The following is a description of a gene set: from publication Chen Y, Wang X (PMID 31504780) studied in species Homo sapiens Genes predicted to be targets of miRBase v22 microRNA hsa-miR-12123 in miRDB v6.0 with MirTarget v4 prediction scores > 80 (high confidence targets). Human Gene Set: MIR12123, and this is the list of marker genes: MMP2, GLT8D2, WDR43 (WD repeat domain 43), SCAF4, SLC14A1, RNF103-CHMP3, TBC1D3B, OGFR, DMGDH, CFAP20, FAM200C, ADGRB3, PPP4R4, KIAA1549L, ZC3H12C, ZNF570, ANAPC11, VAMP7, CD163L1, FUT2, ZNF597, MGA, TPR, RPS6KA5, CDK12, SLC7A2, MGAT2, CUZD1 (CUB and zona pellucida like domains 1, NCBI Gene Id 50624), PLCXD3, TFPI2, TMEM59, LGI2, RNF157, SLC10A7, ADCYAP1, ALKBH1, TIGIT, ENKUR, GRB2, PTPDC1 (NCBI Gene Id 138639), NBL1, BACE2, ABRAXAS2, C9orf72, GNRHR (gonadotropin releasing hormone receptor), FMN2, FAM98A, SYT4, SELENOT, FBXO33, GBX2, SKA2, DCDC2, SC5D, UBE2H, GOLIM4, WEE2, CCDC88A, TMEM255A (transmembrane protein 255A), PAQR8, E2F4, SLPI, STT3A, RUNX2, MEP1A, MSR1, CT47A4, SEC62, ITPRID2, GCSAML (germinal center associated signaling and motility like), PSMC6, TBX1, FBXL3, GPR37, USP46, FABP4, CAVIN4, KCNV1, RAB2A, CT47A12, ANO3, SPSB4, ARHGAP6, SLC16A6, COMMD3-BMI1, CAP2, CPE, MPV17L, NCKAP5, PRDM8, ARID1A, CEP20, CT47A11, NUP50, YES1, B3GALNT2, ZNF608, C1D, IRAK3, IFNG, CUL9, UNC80 (unc-80 homolog, NALCN channel complex subunit), REV3L, DYRK1A, LYSET (lysosomal enzyme trafficking factor), MDC1, FUT9, DYNLT5, TNFRSF19, SYT16, UBE2Q2, SLC23A2, MAN1C1, CWC27, SAMD4B, CNTN5, PPP1R12A, CDO1, PPM1L, UGT2B10, ZEB2, HEATR5B, MPDZ, EZH2, KIF3A, PI4K2A, PTPRF, TNPO1, CCDC71L, ADAMTS9, TMX4, ULK2, CDKL2, CNIH2, NR4A2, SUPT6H, CYREN, ZBTB41, HSPA13, TTC14, C8orf34, RB1CC1, QKI, ERLEC1, LZTR1, DAZ2, SSMEM1, SSH2 (NCBI Gene Id 85464), NEK2, ADAM12, SYNRG, RAB9B, NSG1, MAP2, ZNF519, DDX54, NOL3, LYPD6, JAG2, SLC6A15, PAX3, MESP1, SVOPL, GABRA4, SYNE2, TRPA1, ENPP3, MOB1A, MAP3K2, CNGA1, MARK1, NIBAN1, SREK1, LHFPL6, IL17RE, FZD3, NPY2R, PLCB3, RBM26, PRTG (protogenin), PTPN22, MED13, TMEM260, HP1BP3, ATP11C, RAD23A, DENND1B, RRAGA, ZNF737, KBTBD3, SNTG1, IGSF9, GPHN, ZNF678, RAB5IF, PPP1R3A, HS6ST3, KLHL2, USF3, ERP44, SERP1, CFDP1, SIVA1, DOCK5, FRA10AC1, PTPN20, TAF1D, DISC1, C2orf88, MAPK8 (NCBI Gene Id 5599), CDH19, TMX3, ABHD11, BTNL9, TMEM69, NLK, RPRD1B, MYOG, PLP2, GATA3 (GATA binding protein 3), HNRNPDL, NEGR1, CT47B1, SLC25A40, ZNF684, BMI1, GPRASP1, RAB12, IMMT, FTH1, ABHD18, FSTL1, HSF2BP, PRG4, MCM8, MID2, MTMR9, ARHGAP33, DAZ4, VAV2, EYS, DELE1, DCUN1D5, RPL26L1, PSIP1, CT47A8, BCAR3, SRSF4, DBT, BMPR2, SLC15A5 (solute carrier family 15 member 5), CAMSAP2, ANGPT2, MAT1A, BAAT, PHLDA1, SH3TC2, USP5, CREB1, UBE2B, VDAC2 (NCBI Gene Id 7417), ZNF704, SYPL2, GINS4, ELOVL4, NCS1, GPATCH4, BCL2A1, MOB1B, CDC14A, TMEM65, ITGB8 (NCBI Gene Id 3696), ELMOD1, SSNA1, TTC33, CNTN3, GABRB2, MYO19, KMT2C, CEP43, CCR1, ARMCX3, FOXO4 (NCBI Gene Id 4303), STRC, TNFSF8, UBN2, FLRT3, MAT2B, AHCTF1, MTMR6, CMTR2, KIF12, ATP5MG, SCAF11, RNF26, ENAH, SLC17A5, KCMF1, XPNPEP1, TMPO, ADH4, GCSAM, MSC, FOXO6 (forkhead box O6), CRHBP, DST, PLEKHA3, SLC16A7, ALDH6A1, DIXDC1, BEND4, ZNF227, KCNH2 (potassium voltage-gated channel subfamily H member 2), CT47A3, RBM41, PBX3, CT47A9, PCDHB11, BCL2L11, ALDH1L2, LRRCC1, ZNF22, DOCK10, UBE2D3, CWC22, ODR4, DAZ1, SLC1A2, FBXO43, RNF40, PTER, EIF4A1, HAS2, OCRL, MPP4, ACVR2A, TRMT5, SCAI (NCBI Gene Id 286205), RTN1, MDM1 (NCBI Gene Id 56890), DZIP1, LRRC8B, STK38, EIF2S2, EGFLAM, ZSWIM2, OGA, TMEM131L, CT47A7, NUFIP2, LZTS1, CBR4, DIAPH3, CT47A2, ZNF579, IDS, TFRC, NCAPD2, EFNA5, GNL1, CFAP52, RPS6KA6, CREBRF (NCBI Gene Id 153222), G3BP1, SLC25A32, TBX15, MTERF3, TRPS1, SPA17 (sperm autoantigenic protein 17), LEFTY1, YOD1, CSNK1G3, SLC30A10, NUDT19, HAPSTR1, SPATA6, TNIK, JADE1, SLC25A27, SPPL3, TPP2, SERTM1 (NCBI Gene Id 400120), SYNPR (synaptoporin), GAL3ST4, CCDC50, TMEFF2, LRCH2, POLR1F, RPS6KA3, CA8, STK35, LMO7DN, AUH, ZNF585B, NEFM, SLITRK4, PTP4A2, GFPT1, AFAP1, SLC10A4, ZNF544, MERTK (MER proto-oncogene, tyrosine kinase), SQOR, GARNL3, CXADR, CACNA2D1, SBSN, C5orf15, ZNF423, EDRF1 (erythroid differentiation regulatory factor 1), DCLK3, CT47A1, MYOM1, PPP3R1, SMC5, PKP4, RFC3, GPR180, KIF5C, CHMP3, PTPRC, NMB, TNFAIP8, ELAPOR2, STAG2, FKRP, EHMT1, ZC3H12B, NRG1, FAR1, IREB2, CNBP, A2M, RRH, HSD17B6, ZNF572, MARCHF2, PDLIM2, SLC4A2, ZFP30, ERO1A, PRKG1 (NCBI Gene Id 5592), PUS10, HNRNPD, GTF2A1, ADGRL3, GABBR2, DAZ3 (deleted in azoospermia 3), CTTNBP2, CT47A5, BLCAP, GNAI1, ZSWIM5, LATS1, PDPR, ZNF280D, GRID1, PPID, GPR82, SMIM14, TCF7L2, ZNF780B, DDX19A, GIMAP6, TMSB10, PCLO, ZNF626, CLPX, RS1, PLEKHB1, UQCRQ, RBFOX1, CT47A10, SPO11, MAGEA8, BRWD1, OSBPL6, ANKRD28, FAM83B, SMDT1, EMCN, CT47A6, PLEKHF2, PRSS35, KDM5A (NCBI Gene Id 5927), SRI, RUFY3, AHR, MYH15, OTUD1, COPG1, HERPUD2, SPATA31H1, NWD2, CNOT3, TUB, DCAF17, CCSAP (NCBI Gene Id 126731), PAX1, CD8A, DUSP16, PLAG1